Given this list of marker genes Lhpp (NCBI Gene Id 76429), Prune1, Ppa1, Alpl, Ppa2, here is a description of the gene set: species: Mus musculus Mouse Gene Set: GOMF_INORGANIC_DIPHOSPHATE_PHOSPHATASE_ACTIVITY Catalysis of the reaction: diphosphate + H2O = H+ + 2 phosphate.